Given this list of marker genes MIR483, MIR126, BMPER, MIR410, MIR424, MIR27A, BMP4, MIR21, SEMA5A, DLL4, MIR361, MIR26A1, MIR10A, MIR24-1, ACVRL1, JCAD, MIR497, MIR149, APLNR, NGFR, MIR16-1, MIR222, NUS1, MIR27B, IL12A, VEGFA, APELA, MIR132, MIR503, THBS1, EPHA2, MIR101-1, HMOX1, ITGB1BP1, MIR193A, MIR146A, MIR495, MMRN2, MIRLET7B, MIR15A, MIR23A, GATA2, MIR487B, MIR342, PDCD10, FGF2, MIR494, MIR29C, AGTR1, MIR2355, FGFBP1, NRARP, MIR10B, MIR15B (microRNA 15b), PPP1R16B, IL12B, here is a description of the gene set: species: Homo sapiens The multiplication or reproduction of blood vessel endothelial cells, resulting in the expansion of a cell population contributing to sprouting angiogenesis. Human Gene Set: GOBP_BLOOD_VESSEL_ENDOTHELIAL_CELL_PROLIFERATION_INVOLVED_IN_SPROUTING_ANGIOGENESIS